The following is a description of a gene set: Human Gene Set: HP_RETROBULBAR_OPTIC_NEURITIS species: Homo sapiens Retrobulbar optic neuritis Optic neuritis that occurs in the section of the optic nerve located behind the eyeball., and this is the list of marker genes: IL12A (interleukin 12A), C4A, STAT4, MEFV, IFNGR1, CCR1, UBAC2, ERAP1, NLRP3 (NCBI Gene Id 9558), PRORP, HLA-B, NOD2, TLR4, KLRC4, IL10, IL12A-AS1, FAS, IL23R